The following is a description of a gene set: A tendency to fall or the inability to keep oneself from falling; imbalance. The retropulsion test is widely regarded as the gold standard to evaluate postural instability, Use of the retropulsion test includes a rapid balance perturbation in the backward direction, and the number of balance correcting steps (or total absence thereof) is used to rate the degree of postural instability. Healthy subjects correct such perturbations with either one or two large steps, or without taking any steps, hinging rapidly at the hips while swinging the arms forward as a counterweight. In patients with balance impairment, balance correcting steps are often too small, forcing patients to take more than two steps. Taking three or more steps is generally considered to be abnormal, and taking more than five steps is regarded as being clearly abnormal. Markedly affected patients continue to step backward without ever regaining their balance and must be caught by the examiner (this would be called true retropulsion). Even more severely affected patients fail to correct entirely, and fall backward like a pushed toy soldier, without taking any corrective steps. Human Gene Set: HP_POSTURAL_INSTABILITY studied in species Homo sapiens Postural instability, and this is the list of marker genes: ATP13A2, PINK1, GBA1, PMP22, PDGFB, SYNJ1, LRRK2, KCNC3 (potassium voltage-gated channel subfamily C member 3), ACBD6, CSF1R, EZH2, KCND3, TUBG1, KCNQ2, SCN2A, CACNB4, LCA5, DNAJC13, ERCC6, SNCAIP, NIPA1, TRPC3, NR4A2, NIPA2, MME, MAB21L1, FBXO7, PRRT2, UCHL1, CACNA1A, VPS13C, CHCHD2, VPS35, PARK7, CXCR4, SLC30A10, PLA2G6, COQ4, RAB39B, KCNA1, SNCA, MT-TT, ATXN2, ABCC6, ATP1A3, CACNA1C, OPHN1, ADH1C, NF2 (NF2, moesin-ezrin-radixin like (MERLIN) tumor suppressor), SLC20A2, MAPT, RNASEH1, MPV17, RFC1, LRAT, ERCC8, TAF1, ABCB7, STUB1, SDHA, ENPP1, SCN1A, PDGFRB, ATN1, RUBCN (NCBI Gene Id 9711), NPHP1, TIMM8A, ADAT3 (adenosine deaminase tRNA specific 3), GARS1, COL4A1, ALDH18A1, PRKN (NCBI Gene Id 8004), ATP1A2 (ATPase Na+/K+ transporting subunit alpha 2), PNKP, EIF4G1, ERCC4, ATXN8OS, ABCC9, DDHD1, ERCC1, PTRHD1, COQ2, TBP, SPATA7, GIGYF2, SPG7, PODXL, PRKAR1B, POU3F3, RPE65, HTRA2, FMR1, ENSG00000288330, DNAJC6, ATXN3